The following is a description of a gene set: studied in species Mus musculus Mouse Gene Set: GOCC_VACUOLAR_LUMEN The volume enclosed within the vacuolar membrane., and this is the list of marker genes: Hpse, Neu4, Acp2, Nsg1, Hgsnat, Dapk2, Rnaset2b, Manba, Epdr1, Pld3, Scarb2, Hexb, Fasl, Gba1, Ids, Zp3r, Neu1, Rnaset2a, Cubn, Man2b2, Plbd2, Idua, Man2b1, Pdgfrb (platelet derived growth factor receptor, beta polypeptide), Prtn3, Cln5, Gusb, Gaa, Sgsh, Prss57, Naglu, Hspa8, Hexa, Spaca7, Nsg2 (neuron specific gene family member 2), Lamp2, Spata31, Lgmn